Given this list of marker genes HSPBAP1, AKR1B10, PFKFB4, FHOD3, DKK1, FOXQ1, VCAN, GPRC5B, PTPN14, GNG4, MYEF2, NRP1, CHFR, PAM, SMG5, LAMB1, GYG1, HUNK, SLC2A1, NAV3, CTSC, CCDC97, INTS8, TEAD2, HIC2, POU2AF1, SEMA3C, UBAP2L, NEIL3, RBM10, SLC22A15, NPNT, VGLL4, MAP4, CREB3L1, ALDH18A1, UBAP2, RCC2 (NCBI Gene Id 55920), DHRS13, CKMT1B, SERPINE2, here is a description of the gene set: A comprehensive microarray analysis of hepatocellular carcinoma (HCC) revealed distinct synexpression patterns during intrahepatic metastasis. Recent evidence has demonstrated that synexpression group member genes are likely to be regulated by master control gene(s). Here we investigate the functions and gene regulation of the transcription factor SOX4 in intrahepatic metastatic HCC. SOX4 is important in tumor metastasis as RNAi knockdown reduces tumor cell migration, invasion, in vivo tumorigenesis and metastasis. A multifaceted approach integrating gene profiling, binding site computation and empirical verification by chromatin immunoprecipitation and gene ablation refined the consensus SOX4 binding motif and identified 32 binding loci in genes with high confidence. RNAi knockdown of two SOX4 target genes, neuropilin 1 and semaphorin 3C, drastically reduced cell migration activity in HCC cell lines suggesting that SOX4 exerts some of its action via regulation of these two downstream targets. The discovery of 31 previously unidentified targets expands our knowledge of how SOX4 modulates HCC progression and implies a range of novel SOX4 functions. This integrated approach sets a paradigm whereby a subset of member genes from a synexpression group can be regulated by one master control gene and this is exemplified by SOX4 and advanced HCC.Oncogene advance online publication, 26 May 2008; doi:10.1038/onc.2008.168. studied in species Homo sapiens Genes up-regulated in the samples with intrahepatic metastatic hepatocellular carcinoma (HCC) vs primary HCC that also have putative binding sites for SOX4. Human Gene Set: LIAO_HAVE_SOX4_BINDING_SITES from publication Liao YL, Sun YM, Chau GY, Chau YP, Lai TC, Wang JL, Horng JT, Hsiao M, Tsou AP (PMID 18504433)